Given this list of marker genes BCL2, ATP6V0E2, DMXL1, CA7, SLC4A5, ATP6V0D1, CLN6, MAPK3, SLC11A1, CFTR, ATP5F1B, UBE3A, SLC9B1, RAB7A, SLC26A6, TASL, PDK4, ATP4B, TMEM199, CCKBR, TMEM175, SLC4A9, SLC45A2, OCA2, SLC9A9, CLIC4, ATP6V0B, SLC9A5, RAB39A, CCDC115 (coiled-coil domain containing 115), CA2, SLC9A1, LAMP1, ATP6V0C, GPR89A, TMEM165, SLC9A6, AVPR1A, RAB38, SLC4A2, SLC9A8, SNAPIN, CLN5, LRRK2, ATP6V0A4, LAMP2, SLC9C2, EDNRB, VPS33A, SLC12A5, RNASEK, ATP12A, TPCN2, TM9SF4, LACC1, SLAMF8, SLC9C1, FASLG, PDK2, AQP11, ATP1A4, CLCN3 (chloride voltage-gated channel 3), HVCN1, SLC26A3, ATP6AP2, RHCG, SLC9A3, RAB20, ATP6V1H, GPR89B, SLC9A4, GRN, ATP6V1B2, ATP6V0A1, AVP, TMEM106B, SPNS1, SLC4A8, ATP6AP1, ROGDI, SLC4A7, EDN1, ATP6V1A, MAPK1, SLC26A4 (solute carrier family 26 member 4), ATP6V1B1, CHP1, SLC4A4 (NCBI Gene Id 8716), TCIRG1, PPT1, SLC4A3, SLC4A1, SLC4A10, DMXL2, CLN3, SLC9A7, ATP6V0E1, SLC9A2, ATP6V1F, ATP6V0A2, ATP4A, TMEM9, ATP6V1D, CREG1, ATP6V0D2, here is a description of the gene set: species: Homo sapiens Human Gene Set: GOBP_REGULATION_OF_PH Any process involved in the maintenance of an internal equilibrium of hydrogen ions, thereby modulating the internal pH, within an organism or cell.